Given this list of marker genes KRAS, FGF22, FGF3, FGF6, FGFR2, FRS3, NRAS, FGF23, SOS1, FGF9, PTPN11, FGF18, HRAS, FGF5, FGF17, FRS2, FGF1, GRB2, FGF10, FGF8, FGF7, FGF4, FGF2, FGF20, FGF16, here is a description of the gene set: Reactome Pathway: FRS-mediated FGFR2 signaling species: Homo sapiens part of: Downstream signaling of activated FGFR2 The FRS family of scaffolding adaptor proteins has two members, FRS2 (also known as FRS2 alpha) and FRS3 (also known as FRS2beta or SNT-2). Activation of FGFR tyrosine kinase allows FRS proteins to become phosphorylated on tyrosine residues and then bind to the adaptor GRB2 and the tyrosine phosphatase PPTN11/SHP2. Subsequently, PPTN11 activates the RAS-MAP kinase pathway and GRB2 activates the RAS-MAP kinase, PI-3-kinase and ubiquitinations/degradation pathways by binding to SOS, GAB1 and CBL, respectively, via the SH3 domains of GRB2. FRS2 acts as a central mediator in FGF signaling mainly because it induces sustained levels of activation of ERK with ubiquitous expression.<br><br><br>